Given this list of marker genes Rhbg, Rhcg, here is a description of the gene set: This event has been computationally inferred from an event that has been demonstrated in another species.<p>The inference is based on the homology mapping from PANTHER. Briefly, reactions for which all involved PhysicalEntities (in input, output and catalyst) have a mapped orthologue/paralogue (for complexes at least 75% of components must have a mapping) are inferred to the other species. studied in species Mus musculus part of: Miscellaneous transport and binding events Reactome Pathway: Rhesus glycoproteins mediate ammonium transport electronically inferred by orthology from the curated human pathway